Given this list of marker genes H2BC11, H1-1 (NCBI Gene Id 3024), H2AC6, CBX1, SETDB1, H2BC12, HAT1, H2AC8, CHAF1B, BMI1, EZH2 (enhancer of zeste 2 polycomb repressive complex 2 subunit), CENPA, H2BC21, H1-0, KAT6A, H1-2, NASP, H2AC18, H2AZ1, NAP1L3, CHAF1A, H2AX, H2BC13, here is a description of the gene set: studied in species Homo sapiens Human Gene Set: MODULE_189 Genes in the cancer module 189.